Given this list of marker genes TGFB1, ELAVL1, CD177, APP, CRP, PRKCD, ITGB2, SYK, TYROBP, ITGAM, GSTP1, GNAI2, ACP5, SOD1, CLEC7A, PON3, MAPT, AGT (NCBI Gene Id 183), CYBA, FPR2, PRKCE, F2RL1, here is a description of the gene set: Human Gene Set: GOBP_REGULATION_OF_SUPEROXIDE_ANION_GENERATION Any process that modulates the frequency, rate or extent of enzymatic generation of superoxide by a cell. studied in species Homo sapiens